The following is a description of a gene set: Any process that modulates the frequency, rate or extent of the centrosome cycle, the processes of centrosome duplication and separation. Mouse Gene Set: GOBP_REGULATION_OF_CENTROSOME_CYCLE studied in species Mus musculus, and this is the list of marker genes: Mcph1, Spice1, Cep131, Azin1, Atf5, Mdm1, Cenpj, Cep120, Vps4b, Mapk8, Chmp4c, Cdk11b, Nup62, Tmem67, Chmp1b, Chmp1a, Chordc1, Pkhd1, Rbm14, Nubp1, Chmp2a, Sirt1, Kifc1, Xpo1, Gen1, Alms1, Cep76, Kat2b, Cep192, Cenatac, Poc1a, Ppp1r35, Sass6, Xrcc3, Plk2, Rock2, Chmp3, Chmp5, Chmp2b, Ccdc15, Nat10, Npm1, Trim37, Poc1b, Stil, Cep295nl, Ccnf, Kat2a, Ccnl2, Wdr62, Cdk5rap2, Plk4, Pdcd6ip, Fbxw5, Dync1li1, Ccnl1, D7Ertd443e, Chmp4b, Mark4, Cep295